The following is a description of a gene set: studied in species Mus musculus Genes predicted to be targets of miRBase v22 microRNA mmu_miR_34a_3p in miRDB v6.0 with MirTarget v4 prediction scores > 80 (high confidence targets). Mouse Gene Set: MIR_34A_3P from publication Chen Y, Wang X (PMID 31504780), and this is the list of marker genes: Btaf1, Kcnj13, Tgm1 (NCBI Gene Id 69510), Tbc1d9b, Vcl, Parp8, Cdkl2, Scn1b, Irf4, Klhl4, Cntn3, Luc7l, Dnah5, Acbd5, Kcnj6, Gabra1, Ninj1, Ptpre, Oxct1, Mxi1, Gnai1, Degs1l, Plekha8 (NCBI Gene Id 231999), Hsf5, Mmp1a, Nexmif, Pced1a, Plxnc1, Rspo2, Oog4, Tbc1d8b, Snn, Akap11, Cspp1, Dmac2l, Dolk, Zfp93, Rnf44, Tbx20, Slc5a8, Naa40, Ippk, Pja2, Rgs7bp, Rb1cc1, Bcat1, Cab39, Pfn2, Cul4b, Tet3, Fam120c, Fam120a, Abca5, Trmt2a, Septin11, Mtor